The following is a description of a gene set: from publication Fu W, Ergun A, Lu T, Hill JA, Haxhinasto S, Fassett MS, Gazit R, Adoro S, Glimcher L, Chan S, Kastner P, Rossi D, Collins JJ, Mathis D, Benoist C (PMID 22961053) Human Gene Set: GSE40274_CTRL_VS_HELIOS_TRANSDUCED_ACTIVATED_CD4_TCELL_DN Genes down-regulated in CD4 T conv: control versus over-expression of IKZF2. species: Homo sapiens The transcription factor FoxP3 partakes dominantly in the specification and function of FoxP3+ CD4+ T regulatory cells (Tregs), but is neither strictly necessary nor sufficient to determine the characteristic Treg transcriptional signature. Computational network inference and experimental testing assessed the contribution of several other transcription factors (TFs). Enforced expression of Helios or Xbp1 elicited specific signatures, but Eos, Irf4, Satb1, Lef1 and Gata1 elicited exactly the same outcome, synergizing with FoxP3 to activate most of the Treg signature, including key TFs, and enhancing FoxP3 occupancy at its genomic targets. Conversely, the Treg signature was robust to inactivation of any single cofactor. A redundant genetic switch thus locks-in the Treg phenotype, a model which accounts for several aspects of Treg physiology, differentiation and stability., and this is the list of marker genes: SLC52A1, HSD3B1, CNOT6L, MID2, VPS29, TBRG4, TUFT1, PLAA, VEGFA, NR1D2, IER2, CAMK4, UBE2U, TBR1, KCTD5, GOLGA5, ABTB2, COQ8A, GPSM1, CDH24, EGR2, MAB21L1, PADI3, EEF1G, GIT1, SRPRB, AVEN, NLE1 (NCBI Gene Id 54475), LONRF1, HSPA1A, ISG15, LYAR, FAM167A, ECE2, CINP, CAND1, CCL3, ITK, NUBP1, IL3RA, PSMD11, TBL3, SINHCAF, BAX, SLC39A4, PHB2, ZHX2, KRTCAP3, CXCL2, CHST7, XPO4, NETO2, UTP4, SAA2, CMTR2, YAF2, MIR301B, PSAT1, TOMM40, NT5C1B, IFNLR1, CCDC116, PIP5K1C, FLCN, L2HGDH, ATP6V0D2, CRLS1 (NCBI Gene Id 54675), VAT1, SLC25A25, TSSC4, AIMP2, RGS9BP, MIF, MRPS34, NDUFS3, DPP7, AHCTF1, CSNK1D, PTPDC1, GRIA4, ILDR1, NTMT1, PSMD1, ATL2, MRPL36, ST6GALNAC4, IL2RA, TTF2, GPS1, CDHR4, INSM1, EAF2, CNGB1, SET, PSMB5, CRYBA1, QTRT2 (NCBI Gene Id 79691), MIR155, SENP6, CHD1, ALYREF, ETS2, DLK1, BCAR3, RCC1L (NCBI Gene Id 94293), LONRF2, FOXO6, TXNRD1, CCR6, DDX27, SRM, GNL1, SLC3A2, SEL1L2, IDE, KATNA1, PRKCI, RBX1, ANKRD55, NXT1, SRXN1, LIPT2, UNG, IL21R, SNRNP35, PIP5KL1 (NCBI Gene Id 138429), HOMER1, HSPH1, TTLL6, VPS8, RPF2, PPRC1, LYPD4, POLR1C, TIMM50, CC2D1B, SNAI3, VKORC1L1, C1QTNF4, PICK1, RRAD, MRPL44, ATP1A1, STAP1, CDH19, POLR1B, ABCA5, TMEM70, PRMT6, MIRLET7D, ANKIB1, POGK, ARIH2, ADPGK, CHPF, ADO, SLC20A1, PAXIP1 (NCBI Gene Id 22976), PCGF5, SYNGR2, ASXL1, CDC42EP5, IPO4, C2orf49, ANK1, EML5, ELP1, KIF21A, TENT5C, SLC5A3, ITPKB, JUNB (JunB proto-oncogene, AP-1 transcription factor subunit), SS18, PLK3, MIR17HG, PTP4A1, GCH1, SUDS3, GOT1